The following is a description of a gene set: Mouse Gene Set: GOBP_ANTIMICROBIAL_HUMORAL_RESPONSE An immune response against microbes mediated through a body fluid. Examples of this process are seen in the antimicrobial humoral response of Drosophila melanogaster and Mus musculus. studied in species Mus musculus, and this is the list of marker genes: Hmgn2, Reg3b, Ighg3, Pglyrp3, Lgals4, Defb1 (NCBI Gene Id 13214), Gapdhrt, Hamp2, Defa5, Fgb, Cst9, Ccl19-ps6, Gapdh-ps15, Igha, Defa26, Il17f, Pf4, Ccl2, Spag11b, Wfdc11, Pgc, App (NCBI Gene Id 319425), Ccl11, Reg3a, Gapdhrt2, Tslp, Defb21, Ccl27a, Rpl39, Ccl7, Cstdc2, Defa40, Ccl21e, Colec11, Rpl30, H2-T23, Defa17, Wfdc3, Ang6, Ccl21b, Kng1, Cxcl10, S100a9, Defa34, Gata6 (GATA binding protein 6), Rnase4, Ccl9, Defa39, Ighe, Reg2, Leap2, Gapdh, Fga, Ccl22, Cxcl13, Wfdc17, Hmgn2-ps, Pla2g6, Rnase6, Hrg, Ltf, Ccl6, Ccl8, Camp, Ccl19-ps3, Cxcl15, Defa37, Ighg2c, Wfdc10, Defa30, Ccl27b, Defa41, Ccl24, Xcl1, Spag11a, Ccl17, Fam3a, Ppp2r3c, Evpl, Defa31, Ccl26, Wfdc2, Spon2 (NCBI Gene Id 76474), Pglyrp1, Ang4, Tac1, Ccl21f, Cxcl12, Lgals3, Ccl19, Rps19, Elane, Ccl19-ps4, Wfdc15a, Defa2, Klk7, Ccl27al (C-C motif chemokine ligand 27A like), Reg3d, Bpifa5, Ighg2b, Trf, Npy, Ppl, Pla2g1b, Il17a, Wfdc21, Reg1, H2bc21, Adm, Wfdc15b, Ang2, Kng2, Klk5, Wap, Ccl5, Ighg1, F2, Wfdc13, Defb22 (defensin beta 22), Reg3g, Ctsg, Vip, Ang5, Ccl1, Nts, Defa28, Bpi, Ccl19-ps5, AY761185, Pomc, Wfdc16, Inhca, Mmp7, Sprr2a1 (NCBI Gene Id 20755), Defa35, Defa42, Gm5849, Wfdc12, Ivl, Dmbt1, Ccl20, Defa23, Galp, Wfdc9, Defa24, Ccl12, Ccl21d, Defa3, Defa29, Defa22, Rarres2, Wfdc5, Defa21, Ang, Defb37, Ccl25, Ccl3, Bcl3, Cxcl5, Krt6a, Ccl21a (NCBI Gene Id 18829), Cx3cl1, Cxcl11, Bpifa1, H2bc12, Ccl19-ps1, Ighm, Romo1, Nppb, Defa25, Pglyrp4, Defa38, Ccl28, Ccl4, Cxcl9, Defa20, Slpi, Nod2, Acod1, Il36rn, Hamp, Cxcl14, Ppbp, Fau, Jchain, B2m, Wfdc18